Given this list of marker genes SHMT2, ATP6AP2, KIF1A, SLC39A14, KIF5A, FARS2, ERCC6, FBXO7, ARL6IP1, AMPD2, RETREG1, here is a description of the gene set: Human Gene Set: HP_SPASTIC_PARAPARETIC_GAIT Spastic paraparetic gait studied in species Homo sapiens A type of spastic gait in which the legs are usually slightly bent at the hip and in an adducted position. The knees are extended or slightly bent and the feet are in a plantar flexion position. This posture requires circumduction of the legs during walking. The gait may appear stiff (spastic gait disorder) or stiff as well as insecure (spastic ataxic gait disorder). In spastic paraparetic gait, each leg appears to be dragged forward. If the muscle tone in the adductors is marked, the resulting gait disorder is referred to as scissor gait.